The following is a description of a gene set: species: Homo sapiens part of: Metabolism of amino acids and derivatives The major pathway of histidine catabolism, annotated here, proceeds in four steps to yield glutamate and, in the process, convert one molecule of tetrahydrofolate to 5-formiminotetrahydrofolate. Histidine can also be decarboxylated to form histamine. Histidine can also be used to form carnosine (beta-alanyl-L-histidine), an abundant dipeptide in skeletal muscle and brain of most vertebrates. Reactome Pathway: Histidine catabolism, and this is the list of marker genes: HDC, HNMT, CARNMT1, HAL, CARNS1, AMDHD1, UROC1 (urocanate hydratase 1), FTCD, AOC1